Given this list of marker genes NPM1, NUP210, RPL5, RPS5, RPS8, RPS7, TNFAIP8L2, HNRNPF (NCBI Gene Id 3185), UBE2L3, BACH2, RPL26, RPL17, GDI2, SNHG8, GHITM, TBCA, ARPC3, SNRPG, RPS16, PHYH, REXO2, RPL23A, RPL39, EIF3I, HSPA8, RPL31, RPL10, ACTG1, RPL18A, ARF6, RNASET2, ANXA2, MFF, PRDX5, UQCRB, RPS6, TUBA1B, HNRNPA3, RPL7A, RPL14, COX6B1, C3, ZNF296, C12orf57, HADHA, PSME1 (NCBI Gene Id 5720), HINT1, RPL23, IRF4, RPL27A (NCBI Gene Id 84736), OAS2, RPL35, RPL38, RPL37A, RPL3, CSNK1A1, APOBR, VDAC3, OAZ1, CLU, CD68, TMA7, RPS9, PSMB10, PSMD4, SUB1, RPS4X, DAP, EIF4G2, RPS10, PDLIM1, HCLS1, PDHB, NDUFC2, BTF3L4, UBXN8, FERMT3, HNRNPK, RPL12, TPM3, RPLP0, ISG15, ATP6V1C1, PPP1CC, RAN, MRFAP1L1, TPT1, PIM2, RPL7, TRMT112, ZBP1, CXCL16, FXYD5, NDUFS5, NPC2, KXD1, ANP32B, RPS3A, RPS14, LY86 (NCBI Gene Id 9450), RPL18 (ribosomal protein L18), ITGB1BP1, RPSA, ATP5MG, PSMA1, COX6A1, HSPA5 (heat shock protein family A (Hsp70) member 5), TGIF2, EEF1G, TM9SF2, BRK1, RPL36 (NCBI Gene Id 92364), TM9SF3, RPS11, HNRNPC, FABP5, S100A6, RPS21, SET, RPL4, RPS15A, RPL37, RPL6, RPL22L1, SEM1, RPL24, RPS27, RPS23, NTAN1, RPL13A, ITM2C, RPS25, RPL30, UBE2D3, UQCRHL, EIF3H, FCER1G, FCRL1, GYPC, PPIA, LIMD2, RPL9, YWHAE (NCBI Gene Id 7531), RBBP7 (RB binding protein 7, chromatin remodeling factor), EEF1B2, RPL22, CAPRIN1, RPS18, DECR1, NDUFA1, EIF3E, EIF4B, ACTB (NCBI Gene Id 60), PSMB4, LASP1, CHCHD2, RAPGEF6, RPL34, LCK (NCBI Gene Id 95387), MAP1LC3A, PRDX1, SOD1, AEBP2, RPS2, COX5A, AKR1A1, TKT, ESD, YBX1, DAZAP2, HNRNPDL, RPS3, COPZ1, RPS29, HSPE1, RPLP2, GIMAP8, KSR1, LY9, MYL6, RACK1, RPL11, CORO1A, RPL27, RPL13, RPS26, RPL41, IFIH1, RPL28, MORF4L1, IFITM2, ABRACL, KRT7, RPL19, RPS19, ACSL5, ARPC2, KRT77, CARD6 (caspase recruitment domain family member 6), CCT4, here is a description of the gene set: studied in species Homo sapiens Genes up-regulated in polymorphonuclear leukocytes (24h): control versus infection by A. phagocytophilum. from publication Borjesson DL, Kobayashi SD, Whitney AR, Voyich JM, Argue CM, Deleo FR (PMID 15879137) Polymorphonuclear leukocytes (PMNs) were obtained from healthy individuals in accordance with protocols approved by the Institutional Review Board for Human Subjects at the University of Minnesota and the National Institute of Allergy and Infectious Diseases. PMNs (107) were combined on ice with live S. aureus (108) or with live or heat-killed A. phagocytophilum (bacteria isolated from 5x106 infected HL60 cells for a ratio of 1 infected HL60 cell: 2 PMNs, ~ 5-20 A. phagocytophilum: PMN) in wells of a 12-well tissue culture plate (pre-coated with 20% autologous normal human serum). Unstimulated control assays received either buffer (for S. aureus comparisons) or clarified HL60 lysate (for A. phagocytophilum comparisons). Plates were centrifuged at 350 x g for 8 min at 4oC to synchronize phagocytosis and incubated at 37 deg. C in a CO2 incubator for the indicated times. At the indicated times, tissue culture medium was aspirated from the plate and PMNs were lysed directly with RLT buffer (Qiagen, Valencia, CA). Purification of PMN RNA and subsequent preparation of labeled cRNA target was performed as described in Methods. Labeling of samples, hybridization of cRNA with HU133A oligonucleotide arrays (Affymetrix, Santa Clara, CA), and scanning were performed according to standard Affymetrix protocols ( http://www.affymetrix.com/pdf/expression_manual.pdf ). Experiments were performed in triplicate, using PMNs from three healthy individuals for each treatment. Human Gene Set: GSE2405_0H_VS_24H_A_PHAGOCYTOPHILUM_STIM_NEUTROPHIL_UP